Given this list of marker genes UNC45A (unc-45 myosin chaperone A), SZT2, WSCD1, PMEL, CFAP410, ADPRH, PKM, REST (NCBI Gene Id 5978), MAN2A2, TRPV4, CDKN2A-AS1, FOXO4, here is a description of the gene set: This study assessed the possibility to build a prognosis predictor, based on microarray gene expression measures, in stage II and III colon cancer patients. Tumour (T) and non-neoplastic mucosa (NM) mRNA samples from 18 patients (nine with a recurrence, nine with no recurrence) were profiled using the Affymetrix HGU133A GeneChip. The k-nearest neighbour method was used for prognosis prediction using T and NM gene expression measures. Six-fold cross-validation was applied to select the number of neighbours and the number of informative genes to include in the predictors. Based on this information, one T-based and one NM-based predictor were proposed and their accuracies were estimated by double cross-validation. In six-fold cross-validation, the lowest numbers of informative genes giving the lowest numbers of false predictions (two out of 18) were 30 and 70 with the T and NM gene expression measures, respectively. A 30-gene T-based predictor and a 70-gene NM-based predictor were then built, with estimated accuracies of 78 and 83%, respectively. This study suggests that one can build an accurate prognosis predictor for stage II and III colon cancer patients, based on gene expression measures, and one can use either tumour or non-neoplastic mucosa for this purpose. from publication Barrier A, Lemoine A, Boelle PY, Tse C, Brault D, Chiappini F, Breittschneider J, Lacaine F, Houry S, Huguier M, Van der Laan MJ, Speed T, Debuire B, Flahault A, Dudoit S (PMID 16091735) species: Homo sapiens Down-regulated genes in tumor samples from colon cancer patients who developed recurrence of the disease. Human Gene Set: BARRIER_CANCER_RELAPSE_TUMOR_SAMPLE_DN